Given this list of marker genes BMP2, BMP6, AFP, SRD5A1, CYP11A1, AKR1D1, AKR1C1, ADM, DKK3, DHRS9, BMP5, FSHB, WNT4, CYP11B1, EGR1, CACNA1H, STARD3, SCP2, CYP46A1, AKR1C4, AKR1C2, DHRS2, EDNRB, AKR1C3, LHB, TSPO, DGKQ, CYP17A1, HSD17B10, CYP11B2, HSD3B2, HSD3B1, SCNN1B, CLCN2, DAB2, STAT5B, AKR1B1, REST, here is a description of the gene set: Human Gene Set: GOBP_C21_STEROID_HORMONE_METABOLIC_PROCESS species: Homo sapiens The chemical reactions and pathways involving C21-steroid hormones, steroid compounds containing 21 carbons which function as hormones.